The following is a description of a gene set: Human Gene Set: HP_POSTAXIAL_POLYDACTYLY Postaxial polydactyly species: Homo sapiens A form of polydactyly in which the extra digit or digits are localized on the side of the fifth finger or fifth toe., and this is the list of marker genes: OTUD5, NCAPG2, IFT52, BBS2, TMEM237, PIK3R2, WNT7A, KIF7, SUFU, RBBP8, ZNF141, TMEM218 (NCBI Gene Id 219854), SDCCAG8, KIF3B, BHLHA9, KIAA0586, RAB23, H3-3B, SMO, DYNC2I2 (dynein 2 intermediate chain 2), TGFBR1, IFT172, BBS10, CHST11, CCDC28B, BMP4, KIAA0753, TRIM32, CEP290, SETBP1, IFT57, DDX59, RBM10, BBS1, ALX3, GLI2, FLNA, BBIP1, TBX5, BMPR1B, DHCR7, MKS1, PDE6D, EVC2, MBTPS2, RPGRIP1 (RPGR interacting protein 1), TCTN1 (NCBI Gene Id 79600), WDR19, NPHP3, NKX2-6, BBS9, HOXA13, DYNC2I1, CRB2, SMOC1, WDR35, BBS7, TOGARAM1, TGFBR2, SETD5, CSPP1, TCTN3, IFT74, TBX1, INPP5E, GDF6, DYNLT2B, CIBAR1, TXNDC15, C2CD3, FGFR2, GPC3, SC5D, BBS12, MEGF8, B9D2 (B9 domain containing 2), IFT81, CFAP418, KIAA0825, CCND2 (cyclin D2), LBR, IFT27, ARMC9, CC2D2A, SYNGAP1, LZTFL1 (leucine zipper transcription factor like 1), SCAPER, PRKACB, TTC8, NKX2-5, SCLT1, CEP120, PORCN, CD96, AKT3, IFT43, CEP19, GATA6, TMEM216, TMEM67, PRKACA, SCNM1, TMEM231, TTC21B, DYNC2LI1, RAB34, PLAA, MKKS (MKKS centrosomal shuttling protein), BBS5, OFD1, IQCE, MAX, IFT56, IFT80, GLI1, EXTL3, TBX3, GDF5, ARL6, HOXD13, CPLANE1, IFT140, EBP, ZFX, PPP2R1A (NCBI Gene Id 5518), NEK1, BBS4, TMCO1, HYLS1, INTU, DYNC2H1, UQCC2, CILK1, EVC (NCBI Gene Id 7886), TCTN2, GPC4, LMBR1, B9D1, MYCN, HNRNPK (NCBI Gene Id 3190), TMEM107, NPHP1, USP9X, RPGRIP1L, COG6, CTU2, WDPCP, GLI3